Given this list of marker genes IGHE, ITGAM, CD8A, GABRP, PORCN, LRP1B, TRBV6-1, PKD2L1, ITGB7 (NCBI Gene Id 3695), TRBV6-8, BMPR1B, TRAV26-1, CD247, HFE, PKD1L3, MST1R, VLDLR, TRBV10-2, ITGA3, ADGRV1, GPR37L1, PDGFRA, TYK2, GPR156, CALCR, TRBJ2-6, ITGA9, CHUK, TRBV4-1, IL2RA, KLRC3, TRAV7, TRBV10-3, TRBV10-1, TSHR, CD3G, TLR6, CHRFAM7A, TRAV40, HTR2C, LIFR, ITGA7, TRAV9-2, TNFRSF11B, ZAP70, GPR37, MUSK, TRGV4, OLR1, GRIK3, PLXNB2, EMILIN1, GRIK1, GRIN2A, ITLN1, ARNT2, LYN, TRPV3, GFRAL, ADRB2, CACNG7, IL2RG, CHRNA3, ITGA6, ITGA2B, TRGV8 (NCBI Gene Id 6982), TREM2, HTR2A, ADRA2A, LRP8, TRAV12-1, GABRB2, KLRC1, CHRNA1, EPHB4, ITGA5 (integrin subunit alpha 5), TRAV36DV7, GRIN1, TRGV9, LIME1, GPRC5D, CNIH3, CAPRIN2, HTR1B, GABBR2, CD200R1, FLNA, PTPRA, CD36 (CD36 molecule (CD36 blood group)), RXRA, TRBJ2-2, TRBV18, IL6ST (NCBI Gene Id 3572), RAMP3, IL3RA, TRAC, IKBKB (inhibitor of nuclear factor kappa B kinase subunit beta), TRAV21, CEACAM1, TRAV24, TRAV6, NOTCH1, KLRC2, TRBV5-1, BMAL2, LRP1, ITGAL, SMAD3 (SMAD family member 3), AMN, ITGB2, TRAV4, TRBV7-7, TRGV11, TNFRSF1B, TRAF2, GPR160, JAK1, TRAF5 (NCBI Gene Id 7188), CD4, BMPR1A, CHRNA4, TRAV10, TRBV12-4 (T cell receptor beta variable 12-4), PLXNC1, TRBV7-2, TRAV8-3, TAOK2, TRAV26-2, FLT3, GRIK4, APP, TRAV34, NPR1, GRIN2B, RNMT, ITGB4, CHRNA7, ABCG5, MTTP, TAS1R3, DDR2 (NCBI Gene Id 4921), PLXNA3, TRAV1-2, TRBV5-3, GABRA2, ROR2, TRAV35, TNFRSF1A, FLT1, GABRR3, TRDD1, GPR63, TRAV13-1, NR1H3, ENG, GRIA1, TRAF3, TFRC, CRLF1, TRAV16, TRBV6-6, ITGA2, TRPC1, NRN1, KLRD1, TRAV39, CD14, GABBR1, GABRB3, TRBV20-1, GRM7, CSF2RB, GPR101, CACNG2 (calcium voltage-gated channel auxiliary subunit gamma 2), TRBV14, TRBJ1-3, GP1BA, TRBV7-1, TRAV38-1, RIPK1, TRAV22, ERBB3, IFNLR1, IFNAR2, TRBV23-1, FGFR4, ABHD12, NOTCH2, P2RX2, TRAV41, HTR2B, GP1BB, GFRA2, PTPN6, GH1, MERTK, TRBJ1-5, TRGV5, RYK, TRGC2, FSHR, GPRC5C, TRAV5, OLFM3, TRBV30, PTPRN2, INSR, PLA2R1, LEPR, IRS1, PTH1R, KCTD12, TRBV7-4, IFNAR1, ITGAV, PLXNB3, IL4R, NRP1, TRAV14DV4, ITGBL1, NTRK2, GP5, GABRQ, TRBJ1-1, ITGB5, TRAV30 (T cell receptor alpha variable 30), EGFR (epidermal growth factor receptor), PDGFRB, PEX5L, TYRO3, TIE1, TRAV13-2, TM7SF2 (transmembrane 7 superfamily member 2), SHISA9, GABRA5, GPR119, MCOLN1, IL12RB2, STXBP5, TRBV28, CACNG8, ITGA11, CD6, GABRG1, FGFR3, TRBV11-1, BMP2, GRID2, TRBV5-6, TGFBR2, TRBC2, TRBJ2-4, SKAP1, CSF3R, IL5RA, HTR3C, P2RX3, MTNR1A, GABRR1, TRBV5-4, BMAL1, PSG9, CHRNG, TRDJ1, GABRA3, CHRNE, TRDV1, ACVR2A, CD79A, TGFBR3, MET, TRBV6-4, NR1H4, GPRC5A, SLITRK5, GRIN3A, AMHR2, TRBV16, CD3D, ALK, TRGV10, ITGAX, GABRA4 (gamma-aminobutyric acid type A receptor subunit alpha4), TRGV2, IGF1R, TRGC1, TSPAN32, ROR1, TRBV4-2, OLFM2, ALCAM, GRID1, PLXNA2, GFRA4, CHRNB2 (cholinergic receptor nicotinic beta 2 subunit), TRBV3-1, ARNT, PTPRB, AHRR, CD74, TRIL, LDLR, TRBV6-7, TEK, TRBV19, APBB1IP, PLXND1, SDCBP, B2M, SACM1L, PLXNA4, DIABLO, TRDC, TRAV20, AXL, TRAV17, PRLR, TRBV5-5, LOXL4, TRAV9-1, ITGB3, VWC2, TRBJ1-2, GABRA1, TRAV2, GRIN2D, GPR62, ERBB4, SHISA6, TRBV7-3, TRAF6, SCIMP, HSP90AB1, ITGA1, TRAV27, FCRL5, GABRD, PTK2B, CD8B, TRBV2, ABCG8, ACVR1, FGFR1, ITGA10, HTR3B, IL11RA, GRIN2C, TRAV38-2DV8, HTR3D, TRBV11-2, TRBJ2-7, IL31RA, KDR, CACNG5, DRD2, HTR3A, LRP5, TRBV17, KIT, TRBV7-6, IFNW1, TRBV24-1, GRIK2, TRBJ2-5, ITGB1, GFRA1, CNIH2, NBR1, TRAV8-1, CHRNB1, IL12RB1, CD44, PLXNB1, TLR4, SHISA8, SYK, PLXDC1, NRP2, TRAV12-2, TRBV27, ADCYAP1R1, TRAV23DV6, TRAV25, GABRE, CSF1R, TRAV8-4, GPRC5B, INSRR, ITGAD, BIRC2, SHISA7, CUBN, TRBV11-3, IL18RAP, CPT1C, PLXNA1, IL6, GRIA2, RNF31, CHRNA2, GPBAR1, TRAV18, TRAV8-6, CSF2 (NCBI Gene Id 1437), TRBV13, TRGV1, IFNL1, TRAV1-1, IL18R1, RET, TLR2, CHRNA9, LY96, GABRR2, GRM1, TRBV29-1, TRAT1, ACVRL1, RAMP1, CHRNA5, TF, TRBJ2-3, CACNG4, TRBV12-3, RAMP2, ITGA8, GABRB1, NLGN1, GPR61, GPR20, TRBJ2-1, ADRB3, CR1L, IL2RB, TRAV12-3, CR2, ITPR3, GABRA6, ABHD6 (abhydrolase domain containing 6, acylglycerol lipase), AIP, GRIA3, IL13RA1, DLG3, JAK2, IGHM, OSMR, CRLF2, DRD1, IL23R, FLT4 (fms related receptor tyrosine kinase 4), ERBB2, IL13RA2, VWC2L, NTRK1, PPARG, VIPR1, CHRNA6 (NCBI Gene Id 8973), TRBC1, TLR1, TLR7, ITPR2, TRAV19, GRIA4, TRBV9, TRAV3, TRAV8-2 (T cell receptor alpha variable 8-2), EPS8, TRDV2 (NCBI Gene Id 28517), TRBV7-9, HJV, CD3E, GHR, ITGB6, TRBD1 (T cell receptor beta diversity 1), CSF2RA, ITGA4, CHRND, HTR3E, CALCRL, CHRNB4, TRADD, NTRK3, IMPG2 (NCBI Gene Id 51443), ITGB8, TRAJ3 (T cell receptor alpha joining 3), SEMA4D, ACVR1C, DDR1, CD79B, FGFR2, LRP2, PTPRQ, ACVR1B, GFRA3, TRDV3, TRBJ1-6, PIGR, CACNG3, P2RX6, TFR2, AHR, TRBV5-7, NT5DC3, TRBJ1-4, KCTD16, EPHA1, TRBV6-5 (NCBI Gene Id 28602), VDR, TRBV12-5, GRIN3B, TAS1R2, ACVR2B, TRAV29DV5, GABRG2, GPR84, TGFBR1, LTK, KCTD8, TLR10, IL10RB, DLG4, IL6R, GP9, NR3C2, GABRG3, CNTFR, HTRA2, CD40, NOTCH3, TRGV3, CHRNB3, ROS1, HSPD1, BMPR2, EPHA2, GRIK5, TRBV25-1 (T cell receptor beta variable 25-1), ITGAE, here is a description of the gene set: species: Homo sapiens Human Gene Set: GOCC_RECEPTOR_COMPLEX Any protein complex that undergoes combination with a hormone, neurotransmitter, drug or intracellular messenger to initiate a change in cell function.